The following is a description of a gene set: Human Gene Set: GOBP_ESTABLISHMENT_OF_MITOCHONDRION_LOCALIZATION The directed movement of the mitochondrion to a specific location. studied in species Homo sapiens, and this is the list of marker genes: HIF1A, NECTIN2, TRAK2, HDAC6, MAPT, KIF1B, MAP1S, OPA1, UCHL1, HSBP1 (NCBI Gene Id 3281), KIFBP, PKD1, FEZ1, SYBU, UBB, EPCIP, MARK1, MAP1B, SPAST, MYO19, ACTR10, MGARP, RHOT2, TRAK1, WASF1, TSPAN9, KIF5B, AGTPBP1, AGBL4, LRPPRC, ARMCX3, UXT, RHOT1, NEFL, DNM1L